The following is a description of a gene set: studied in species Homo sapiens The leaflet the plasma membrane that faces the cytoplasm and any proteins embedded or anchored in it or attached to its surface. Human Gene Set: GOCC_CYTOPLASMIC_SIDE_OF_PLASMA_MEMBRANE, and this is the list of marker genes: AJAP1, TRAF3, TRAF5, MCF2L, GNA11, GNGT2, ASPSCR1, ANK1, GNAT3, CHMP4BP1 (charged multivesicular body protein 4B pseudogene 1), SNX5, PKP4, ESYT3, STAC2, FARP1 (FERM, ARH/RhoGEF and pleckstrin domain protein 1), DSG1 (NCBI Gene Id 1828), SAMD12, GNAI3, CDK16, SPTA1, SLC4A1, ESYT2, GNG13, NLRP10, TRAF6, RASA3, GNG7, STAC, AKAP5, KIT, GNG4, FRMD1, GNG11, ALOX15, HTRA2, OSBPL2, GNG10, GNG14, PTPN22, KRAS (NCBI Gene Id 3845), FERMT2, GNG5B, PTPN3, PALM, DNAJA3, CYTH1, HCK, AP2B1, TYK2, GNB1, LILRB4, CD2, GNA14, SYAP1, GNGT1, PGM5, FES, PTEN, GNG3, KCNAB1, PTPN4, RAB21, ATP2C2, CNR2, C2CD2L, DLG1, RGS2, TGM3 (NCBI Gene Id 7053), SAMD10, CHMP7, DIABLO, GNAZ, MYZAP, PLEKHA4, NCF1, TRAF3IP2, MTSS1, JAK3, STAC3, SPTB, CARMIL2, PTPRC, GNB2, GNA13, MAP2K2, LYN, GNAI1 (NCBI Gene Id 2770), GNG8, GNAO1, GNAQ, PTP4A1, GNG5, GNB3, FADD, RASGRP4, JAK2, AP2A1, CHMP4B, LITAF, PTPN7, CHMP4A, GNAI2, MYH10, AP2S1, FRMD6, IKBKB, SHROOM4, NTSR1, DTNA, MTSS2, SOCS3, CHUK, GNG2, LDLRAP1, S100A6, GNAT2, BIRC2, RGS1, GNA12, GNAT1, KCNAB2 (NCBI Gene Id 8514), PPP1R9B, IQGAP1, AP2A2, MYD88, CYLD, KCNIP1, PRMT8, AP2M1, GNB4, TIRAP, RACGAP1 (NCBI Gene Id 94651), FER, EPN3, GEM, GNAL, ACP1, JUP, GNG12, RHOA, EFCAB7, TH, PPP3CA, GNAS, RGS8, SNX18, JAK1, TRAF2, GM2A, SYT6, CDH1, CACNB4 (NCBI Gene Id 785), GPHN, NPHS2, MIEN1, GNA15, TRADD, GNB5, G6PD (glucose-6-phosphate dehydrogenase), RNF31, CHMP4C, MYH9